Given this list of marker genes PSMA1 (NCBI Gene Id 5682), TNFSF8, UBA3, BIRC3, TNFSF18, PSMB4, PSMC5, TRAF2, CD40, TNFSF13B (TNF superfamily member 13b), SEM1, TNFRSF17, PSMB6, TNFSF14, FASLG, PSMD3, PSMB5, TNFRSF6B, PSMD11, TNFRSF4, BIRC2, PSMB2 (NCBI Gene Id 5690), PSMD13, ADRM1, PSMD6, PSMA5, TNF (NCBI Gene Id 7124), BTRC, PSMC2, TRAF3 (NCBI Gene Id 7187), UBE2M, LTB, PSMA4, EDA2R, TNFRSF13C (TNF receptor superfamily member 13C), TNFSF4, TNFRSF8, TNFRSF1A, TNFRSF9, PSMB1, LTA (NCBI Gene Id 4049), PSMC4, PSMD12, PSMD7, TNFRSF13B, PSMD8, RELB (NCBI Gene Id 5971), TNFRSF25, CD40LG, UBA52 (NCBI Gene Id 7311), TNFRSF18, TNFSF13, CD70, TNFSF9, TNFRSF1B, EDARADD, NFKB2, PSMD1, PSMA3, UBB, TNFRSF11A, TNFRSF14, TNFRSF12A, FBXW11, TNFSF12, PSMD14, CHUK, PSMC3, RPS27A, PSMD2, PSMB3, PSMA2, TNFSF15, PSMB7, SKP1, LTBR, EDA, PSMC1, CUL1, PSMA7, TNFSF11, MAP3K14, CD27, TNFRSF11B, EDAR, PSMA6, UBC, PSMC6, here is a description of the gene set: TNFR2 non-canonical NF-kB pathway Human Gene Set: REACTOME_TNFR2_NON_CANONICAL_NF_KB_PATHWAY studied in species Homo sapiens